The following is a description of a gene set: Human Gene Set: WP_HALLMARK_OF_CANCER_SUSTAINING_PROLIFERATIVE_SIGNALING species: Homo sapiens Hallmark of cancer: sustaining proliferative signaling, and this is the list of marker genes: RPTOR, REL, NFKBIA, PTK2 (NCBI Gene Id 5747), SALL4, KIT, CCND1, AKT2, SHC1, SOS2, MAPK1, GSK3B, SOS1, RHEB, PTEN, TSC2, PIK3CD (phosphatidylinositol-4,5-bisphosphate 3-kinase catalytic subunit delta), BRAF, STAT3, WNT1, FLT3, KDR, IKBKG, NTRK2, CHUK, FGFR3, TEK, RUNX1T1, MET, KSR1, MYC, JAK2, TP53 (tumor protein p53), ZBTB16, PDGFRA, GRB2, LEF1, PPARD, RARA, IL6R, AKT1S1, APC, TCF3, PIK3CB, CSNK1A1, BCL9, EGFR, MTOR (NCBI Gene Id 2476, mechanistic target of rapamycin kinase), FLT4, FOXO1, PIK3CA, RELA, CDKN1A, NGFR (NCBI Gene Id 4804), JUP, EPHA2, AKT3, RETN, IL6, LRP5, MDM2, MAP2K2, RAF1, PYGO1, FGFR1, FZD6, FGFR2, MAP2K1, INSR, DEPTOR, KRAS, JUN, NFKBIE, AXIN2, TSC1, SRC, AKT1, IGF1R, FGFR4, CTNNB1, FOS, FLT1, TTI1, NTRK1, IKBKB, LRP6, HRAS, PDGFRB, MLST8, TELO2, ULK2 (unc-51 like autophagy activating kinase 2), ELK1, MAPK3, PML, GAREM2, NFKB1, CSF1R, PIK3CG